The following is a description of a gene set: studied in species Homo sapiens Abstract of publicaton: CD4/CD8 double-positive (DP) thymocytes express the transcriptional repressor Histone Deacetylase 7 (HDAC7), a class IIa HDAC that is exported from the cell nucleus after T cell receptor (TCR) engagement. Through signal-dependent nuclear export, class IIa HDACs such as HDAC7 mediate signal-dependent changes in gene expression that are important to developmental fate decisions in multiple tissues. We report that HDAC7 is exported from the cell nucleus during positive selection in thymocytes, and regulates genes mediating the coupling between TCR engagement and downstream events that determine cell survival. Thymocytes lacking HDAC7 are inefficiently positively selected due to a severely shortened lifespan and exhibit a truncated repertoire of TCR Jalpha segments. The expression of multiple important mediators and modulators of the response to TCR engagement is altered in HDAC7-deficient thymocytes, resulting in increased tonic MAP kinase activity that contributes to the observed loss of viability. Remarkably, the activity of Protein Kinase D, the kinase that mediates nuclear export of HDAC7 in response to TCR signaling, is also increased in HDAC7-deficient thymocytes, suggesting that HDAC7 nuclear export governs a self-sustaining auto-excitatory loop. These experiments add to the understanding of the life/death decision in thymic T cell development, define a novel function for class IIa HDACs, and point to a novel feed-forward mechanism whereby these molecules regulate their own state and mediate stable developmental transitions. Title of manuscript: Nuclear Export of Histone Deacetylase 7 During Thymic Selection Mediates Immune Self-tolerance. abstract of manuscript: Histone Deacetylase 7 (HDAC7) is a TCR signal-dependent regulator of differentiation that is highly expressed in CD4/CD8 double-positive (DP) thymocytes. Here we examine the effect of blocking TCR-dependent nuclear export of HDAC7 during thymic selection, through expression of a signal-resistant mutant of HDAC7 (HDAC7-delta-P) in thymocytes. We find that HDAC7-delta-P Transgenic thymocytes exhibit a profound block in negative thymic selection, but can still undergo positive selection, resulting in the escape of autoreactive T cells into the periphery. Gene expression profiling reveals a comprehensive suppression of the negative selection-associated gene expression program in DP thymocytes, associated with a defect in the activation of MAP kinase pathways by TCR signals. The consequence of this block in vivo is a lethal autoimmune syndrome involving the exocrine pancreas and other abdominal organs. These experiments establish a novel molecular model of autoimmunity and cast new light on the relationship between thymic selection and immune self-tolerance. Goal of Microarray experiment: We did these experiments to determine how alteration of the function of HDAC7, a site-specific and signal-dependent repressor of transcription, changes gene expression in CD4/CD8 DP thymocytes. from publication Kasler HG, Young BD, Mottet D, Lim HW, Collins AM, Olson EN, Verdin E (PMID 21398603) Genes down-regulated in double positive thymocyte from OT-2 transgenic mice: control versus HDAC7 deltaP form after injection with agonist peptide. Human Gene Set: GSE26488_CTRL_VS_PEPTIDE_INJECTION_HDAC7_DELTAP_TG_OT2_THYMOCYTE_DN, and this is the list of marker genes: ERRFI1, CHST2, PEX6, RRAD, ISL1, DPM3, NPHP1 (nephrocystin 1), TOM1L1, PRMT1, NID2, PURA, SHC1, KAZALD1, CMTM3, WDR45B, NME1, CCT6A, PLK2, TRMT1, FLOT1, TNFSF10, TDRP, UNC119, HYAL2, SELE, TAX1BP3 (Tax1 binding protein 3), BGN, NPNT, PDLIM1, TTC3, SYNPO (NCBI Gene Id 11346), MAN1A1, SART3, GYS1, KCTD10 (potassium channel tetramerization domain containing 10), MAGED1, EFNA4, DNAJB1, FLOT2, CFL2, GEM, AKR1B15, TPD52, MAFK, OAT, CPXM1, MYD88, CDCA5, CARM1, ATG2A, EIF3D, VSNL1, CCN2, CLPB, ARID1A, THOC3, EXOC7, MRE11, MPRIP, EIF4E, RCAN3, RPL22, ATM, PLPBP (NCBI Gene Id 11212), MACROH2A1, BTG2, UGCG, ISYNA1, ZFP36, ZNF598, GCSH, CAPNS1, ESYT1, BMP1, RGL2, SPEF1, SPARCL1, PTPN18, DDR1, UBE2D3, TMEM106C, HSPBP1, RALGDS, MRPL14, STEEP1 (STING1 ER exit protein 1), CRK, P2RX6, PTK2, DES (desmin), SPARC, RO60, UNC45A, GALNT2, MCM7, DGUOK, PPP1R14B, PAWR, DIPK1B, MRPL52, KIF1C, CIAPIN1, OTUD7B, RCN1, FERMT2, BPNT2, G0S2, TIPARP, IRS2, ZFP90, HEY1, BSG, ANP32A, IL13RA1, JCHAIN, ATXN10, CHGA, HCK, RNPEPL1, GABPA, RNPS1, TBCA, CHMP3, UBXN4, ADM, RPP21 (ribonuclease P/MRP subunit p21), AMPD3, IPO4, THBS3, MATN4, ELOC, GRN, POLD1, CSTPP1, ANK3 (NCBI Gene Id 288), LIMA1, RPL7, TPT1 (tumor protein, translationally-controlled 1), MBD3, APOE, RWDD1, LAGE3, HSF1, PIAS3, COL19A1, SPRR2A, STT3B, STAT1, GRK6, ANXA1, RBMS2, ZFAND5, AGAP3, GBP4, GLG1, CPNE3, ZNF821, ANAPC1, CBR3, ADAR, SMO, ZC3HC1, B3GALT6, UTP20, RGS3, CSAD, PIK3R2, IGHM, ACVR2A, MAN2B1, SNX17, SLC50A1, MRPS31, AP1S2, IFNGR1, ZNF746 (zinc finger protein 746), RBP1, RANBP3, TSPAN7, POLR2D, CERS2, FGF11, LATS2, FOSB, DCN, TINAGL1, IRAK1, IRX3, SLC1A5, SNTA1, ATRAID, RPS8, RBPJL, DDHD2, WDR83OS, TRIM47, RHBDL3, RYK, MMS19, SLC22A17, TENM1